The following is a description of a gene set: Genes in the hypoxia signature, based on analysis of 11 neuroblastoma cell lines in hypoxia and normal oxygen conditions. Human Gene Set: FARDIN_HYPOXIA_11 from publication Fardin P, Barla A, Mosci S, Rosasco L, Verri A, Versteeg R, Caron HN, Molenaar JJ, Ora I, Eva A, Puppo M, Varesio L (PMID 20624283) Hypoxia is a condition of low oxygen tension occurring in the tumor microenvironment and it is related to poor prognosis in human cancer. To examine the relationship between hypoxia and neuroblastoma, we generated and tested an in vitro derived hypoxia gene signature for its ability to predict patients' outcome. species: Homo sapiens, and this is the list of marker genes: AK4, TPI1, ANGPTL4, FUT11, NDRG1, BNIP3L, PLOD1, KDM3A, IGFBP3, SLC2A3 (solute carrier family 2 member 3), PFKFB4, MAPT, ANKRD37, BTG1, EGLN3, PDK1, FAM162A, VEGFA, TNIP1, TXNIP, BNIP3, EGLN1, ALDOC, P4HA2, PGM1, PGK1, ZNF395, MTFP1, MXI1, DDIT4 (NCBI Gene Id 54541), IGF1R (insulin like growth factor 1 receptor), BHLHE40